Given this list of marker genes NPFF, ERC2-IT1, NOS2, ZNF157, CYP2D6 (NCBI Gene Id 1569), ATXN3, COLGALT2, SLC6A2, ZNF133, CEP162, IL5, ZNF141, TPD52, DGCR5, BRCA1, MC5R, KRT34, ZNF202, CDC73, POU6F1, AMMECR1, NMT2, SLC46A3, ABO, FNTB, PHLDB1, SLC18A1, KRT33A, PVR, NR3C2, PSG1 (NCBI Gene Id 91730), CYP11A1, KRT86, UBE4B, BNIP1, ATP10B, PHF10, GNG4, COX6A2, PRIM2, ZBTB14, GUCY2C (guanylate cyclase 2C), CACNA2D1 (NCBI Gene Id 781), ADAM20, CYP2E1, ATP6V0A2, R3HCC1L, GCM1, SUPT3H, ELAVL2, ATF2, NRTN, HNF1A, CCL16, PLPPR4, JRK, WBP4 (WW domain binding protein 4), NFAT5, ATP8B1, TMEM26, POU6F2, SLC4A3, ABCC8, KLHL18, DNAJC16, PAXIP1, MSH3, GRIK1, PRKCA, MSL3, SPA17, RAD51D, NHEJ1, SLC2A1, TFDP2, RBMXL1, CELA2B, POLR2K, ITIH3, ZNF266, CDYL, NRP2, EDIL3, COL19A1 (NCBI Gene Id 7950), PPP2R5B, SULT2B1, SLC6A11, OPRL1, TBX5, PIK3CB, RPS6KA5, TENM4, FAS, TBC1D22A, POLR1HASP, ABCB10, SIM2, DRC3 (dynein regulatory complex subunit 3), SYT5, HOXD4, P2RY10, TSPAN2, NTNG2, CAMK4, H3C6, CADM4, ABCB1, KDR, GLE1, AQP7, RORB, PPP1R1A, GPR171, PHOX2B, ZBTB33 (NCBI Gene Id 10009), AMOT, C1orf216, KRR1, MAGEA8 (NCBI Gene Id 4107), ZNF33B, TBX19, NR1I2, ZNF134 (NCBI Gene Id 7693), LY9, IL16, JRKL (NCBI Gene Id 8690), TSSK2, SGPL1, PART1, SERPINA4, JADE3, MFN1, TRIM24, ERC1, ZNF200, BARX2, ZBTB22, RXRG, POFUT2, DBT, COL8A1, CLCN3, GUCY2F (NCBI Gene Id 2986), LPGAT1, CFH, PCM1, IGKV7-3, AOC4P, AFF2, RAP2C, IL11RA, CPEB3, SLC22A6, MDM2, BMP10, POLR3F, BRINP3, SULT4A1, PLEKHB1, FBXL4, PGM3, ADCY3, CYP4F2 (cytochrome P450 family 4 subfamily F member 2), ERCC4, BCL2L11, ARL3, HCRTR2, GPR18, GPATCH8 (G-patch domain containing 8), FAM13A, FSHR, ARFGEF2, FZD5, ZBTB40, SLC33A1, CXCL5, GRIK5, KLRC4, FOSL1, LORICRIN, EPHB2, EXOC4, SLC15A1, FIG4, GJB5, TMEM11, GPLD1, SGCD, PAX9, PIK3C2A, PAX6 (NCBI Gene Id 5080), IPO9, PTEN (phosphatase and tensin homolog), OPLAH, PRELID3A, NR2C1, BICD1, CASP10, PTPRB, CRHR1, ADAMTSL3, OR2B6, MLLT10 (NCBI Gene Id 8028), TBXT, IL13, GHRHR (growth hormone releasing hormone receptor), LTBP4, GABRB2, ZP2, CCR3, NXPE3, RREB1, SLC4A8, COQ7, KCNA5, RB1CC1, RUNX2, RYR3, HTR1E, GPR15, SURF2, KNG1, FGF18, NF1, EN2, CPB2, SPATA2, ESR1, KRT2, MAGEA9, ASB4, TANC2, GPR19, PDE6A, FRYL, ITIH1, CTRL, ZNF500, MON2, here is a description of the gene set: Neighborhood of IL16 interleukin 16 (lymphocyte chemoattractant factor) in the MORF expression compendium Neighborhood of IL16 Human Gene Set: MORF_IL16 species: Homo sapiens